Given this list of marker genes Npy, Ccl21e, Notch2, Cd74, Necab2, Prkcz, Cysltr2, Fgf8, Akap12, Tirap, Ccr1, Casr, Fgf20, Cd36, Fgf1, Slamf1, Garem1, Pdgfd (NCBI Gene Id 71785), Gpnmb, Ccn2, Fgfr4, Kdr, Rapgef1, Fgf21, Fpr-rs4, Npsr1, Arrb1, Hras, Gas6, Ccl3, Ccl21a, Drd2, C3, Esr2, Ccl19-ps4, Esr1, Igf1, Tek, Erbb4, Ffar4, Adam17, Angpt1, Chi3l1, Gpbar1, Nelfe, Hcrtr1, Cxcl17, Tgfb1, Arrb2, Tnfsf11, Abl1, Mfhas1, Src, Ccl21d, Cflar, Egf, Prxl2c, Bmper, Ndrg4, Pla2g5, Mapk3, Fga, Fshr, Htr2a, Itgb3, Gcg, Phb2, Dstyk, Cavin3, Dnajc27, Fgf23, Fpr2, App, Apoe (apolipoprotein E), Gnai2, Egfr, Fpr-rs6, Lrp1, Ccl21f, Mt3, Prkca, Cd44, Ccr1l1, Hmgcr, Nod1, Adora2a, Npy5r, Dcc, Nrxn1, Marco, Serpinf2, Htr2c, Map3k12, Ccl19-ps5, Bmp4, C5ar1, Adcyap1, Ccl21b, Ptk2b, Fgf2, Fgfbp3, Ntsr2, Ramp3, Prkd2, Mturn, Hmgb1, Sstr4, Gcnt2, Fgf15, Cxcl12, Mos, Il1b, Crkl, Abl2, Ins2 (NCBI Gene Id 16334), Tnfrsf11a, Dennd2b, Pde8b, Glipr2, Ripk2, Ednra, Apela, Fgf10, Pten, Adra1a, Vegfa, Shc1, Tpbg, Card9, Mif, Acta2, Ager, Trem2, Nodal, Alox15, Hand2, Fgb, Ptprc, Fermt2, Epor, F2rl1, Camk2d, Pdgfc, Pdgfra, Fgf4, Ackr3, Ptpn11, P2ry1, Epo, Tlr2, Alkal2, Scimp, Atp6v0c, Ntrk1, Nptn, Fgg, Gpr55, Map2k7, Phb1, Map2k1, Tlr4, Pdgfa, Fgfr3, Htr2b, Jun, Cxcr4, Nod2, Npnt, Ptpn22, Chrna7, Ccl19-ps6, Calcr, Ngf, Thpo, Il6, Abca7, C1qtnf3, Pdgfrb (platelet derived growth factor receptor, beta polypeptide), Oprm1, Notch1, Cd4, Trpv4, Gpr183, Fpr-rs3, Or2at4, Arhgap8, Bmp2, Fbxw7, Alkal1, Fpr-rs7, Tnfaip8l3, Nrp1, Myh9, Flt4, Rap1b, Slc30a10, P2ry6, Pla2g2a, Rap1a, Pde8a, Fgf18, Nrg1, Tff2, Inhba, Iapp, Ccl19-ps1, Rasgrp1, Spry2, Dusp15, Sema7a, F2r, Icam1, Il1a, Gper1, Csf1r, Pdgfb, Nox4, Pycard, Vegfb, Ddr2, Rapgef2, Havcr2, Braf, Nqo2, Ccl19, Nampt, Fgfr2, Cib1, Ccl19-ps3, here is a description of the gene set: Mouse Gene Set: GOBP_POSITIVE_REGULATION_OF_ERK1_AND_ERK2_CASCADE Any process that activates or increases the frequency, rate or extent of signal transduction mediated by the ERK1 and ERK2 cascade. studied in species Mus musculus